Given this list of marker genes Pcbp4, Rapgef2, Dock9, Psd3, Ebf3, Dlgap1, Pals1, Ndfip2, Slc44a3 (NCBI Gene Id 213603), Glis3, Plce1, Polr3g, Abhd17c, Naa40 (NCBI Gene Id 70999), Snx8, Ubd, Qpctl, Ogt, Ggct, Smcr8, Adcyap1, Ankrd28, Usp31, Snx27, Marchf1, Elmo1, Mpzl2, Tmem144, Bcr, Cabp1, Ttpa, Naa50, Onecut2, Cyyr1, Izumo3, Spsb4, Garre1, Ap1g1, Myo5a, Ctnnbip1, Mogs, Pcsk5, Epn3, Ptpn12, Scamp3, Mfsd2a, Aco1, Tgfbr2, Gmfb, Tspan6, Pan2 (PAN2 poly(A) specific ribonuclease subunit), Twist2, Cachd1, Rgs7, Myrf (myelin regulatory factor), Ythdc1, Plcl2, Csn2, Klhl38, Senp2, Camsap2, Dab2, Abracl, Rasa1, Krt75, Erbb4, Net1, Crkl, Pi4k2b, Ptgfr, Rnf170, Rev3l, Fam135a, H1f0, Nsun4, Srgap2, Stam, Camk2d, Yes1, Prdm1, Arf6, Grb10, Srgap1, Actg1, Rbak (NCBI Gene Id 57782), Etaa1, Qser1, Naa15, Abcb10, Phactr2, Lrif1, Spats2, Ddx17, Cd28, Ssh2, 5031439G07Rik, Pmp22, Abr, Slc16a1 (solute carrier family 16 (monocarboxylic acid transporters), member 1), Usp32, Slc39a2, Arpc5, Kif21a, Abca1, Slco1a4, Zfp110, Rtkn (NCBI Gene Id 20166), Ino80, Grpel2, Osbpl1a, Angpt2, Nudt7, Adpgk, Acsl4, Abcf3, Ddc, Tent5d, Mest, Zcchc4, Noxo1, Serinc5, Fli1, Slc35f5, Mdfic, Nr4a2, Tmem167, Cpeb1, Erlin1, Frrs1, Dusp6, Epb41l5, Socs7, Lnpk, Rabepk, Myl12a, Magi2, Atxn2, Rufy2, Sema3a, Cdk6, Xrn1, Erg, Tmem178, Actb, Dlc1, Tmod1, Mrtfb (NCBI Gene Id 239719), Cbfb, Abhd17b, Ivns1abp, Ythdf2, Fscn1, Gabarapl2, Rpa1, Ccdc25, Krtap4-25 (NCBI Gene Id 76470, keratin associated protein 4-25), Zfhx4, Sirpa, Zbtb10, Rreb1, Tex16, Tbc1d12, Ppp3ca, Slc35d1, Mon2, Cdo1, Nedd9, Cacna1d, Asap2, Slc7a8, Flrt3, Rasa2, Camk1d, Slitrk4, Nuak1, Itpripl2, Sox9, Arap2, Usp46, Urgcp, Nectin3, Rc3h1, Tm9sf4 (NCBI Gene Id 99237), Ldlrad3, Prkx, Ntn4, Fam174b, Gatad2a, Mtrfr, Glis1, Ctnnd1, Irs1, Uba6, Smad3, Smad5, Ccn1, Ppm1a, Vasn, Sp4, Erf, Btg1, Casz1, Kif5c, Unc119b, Ube2d3, Ppp4r2, Hic2, Kcna4 (potassium voltage-gated channel, shaker-related subfamily, member 4), Krtap6-7, Ap2b1, Zfp663, Bach2 (BTB and CNC homology, basic leucine zipper transcription factor 2), Trim2, Insig1, Lancl3, Zfp704, Sun1, Pdcd1lg2, Ece1, Spop, Nufip2, Slc25a36, Ifi44, Sema6a, Rab14, Cntn4, Mosmo, Tagln2, Katnbl1, Flnb, Fkbp3, Pxn, Add3, Gabarapl1, Zfp189, Mkrn3, Efnb3, Arhgap21, Vwa8, Mdga2, Trio, Mtx3, Pdcd4, Mttp (microsomal triglyceride transfer protein), Arhgap15, Dyrk1a, Rin2, Lox, Eri1, Septin11, Snx15, Hnrnph2, Chchd3, Skp1, here is a description of the gene set: from publication Chen Y, Wang X (PMID 31504780) Mouse Gene Set: MIR_145A_5P studied in species Mus musculus Genes predicted to be targets of miRBase v22 microRNA mmu_miR_145a_5p in miRDB v6.0 with MirTarget v4 prediction scores > 80 (high confidence targets).